Given this list of marker genes Tab1, Rps27a, Irak1, Psma1, Usp14, Psmd7, Psmd3, Psmd8, Il18r1, Hmgb1, Psmb2, Nfkb2, Lrrc14, Il1rl1, Mapk8, Psmb7, Psmb6, Map3k7, Psmc4, Gsdmd, Adrm1, Nkiras1, Peli3, Il1rap, Psmb5, Il1a, Tnip2, Irak4, Psma6, Uba52rt, Psmb4, Il33, Psmb1, Traf6, Nfkbia, Psmc5, Ubb, S100b, Psma5, Psma3, Il1rapl1, Casp8, Rela, Nlrx1, Il18, Psmd14, Peli1, Map2k6, Psmc3, Traf2, Il1rn, Il36a, Il1f10, Sqstm1, Map3k3, Ubc, Psma2, Psmd13, Tab2, Psmb3, Psmd1, App, Tollip, Nfkb1, Stat3, Ager, Psmd2, Peli2 (NCBI Gene Id 93834), Irak3, Nlrc5, Usp18, Psmc2, Il18rap, Ube2n, Rbx1, Psmd12, Nkiras2, Psmc1, Psmd6, Tab3, Il36g, Fbxw11, Il36rn, Nfkbib, Ikbkb, Il1r2, Il18bp, Il1b, Casp1, Chuk, Psmc6, Il36b, Psma7, N4bp1, Irak2, Ikbkg, Ctsg (cathepsin G), Tbk1, Tifa, Psma4, Myd88, Ube2v1, Skp1, Map3k8, Il1rl2, Psmd11, Il1r1, Alpk1 (alpha-kinase 1), Uba52, Cul1, here is a description of the gene set: Mouse Gene Set: REACTOME_INTERLEUKIN_1_FAMILY_SIGNALING Interleukin-1 family signaling species: Mus musculus